Given this list of marker genes SCN5A, TRPC1, RFC5, COL9A3, LTBR, DSG2, ROR2, PIR, RAD9A, DEFB4A, SH3GL2, KCNK1, LAMA2, SMAD3, MYOM1, KIR3DL1, KLK6, NCBP1, MAP4K2, GAS6, MZF1, TMED1, ESS2, PDE1B, SLC11A1, BMP1, S100A3, CDKL1, BDKRB2, GET3, ALDH3A1, TBL3, PTGS1, PFKL, ADGRE1, CSPG4, DBN1, LILRB1, NDN (necdin, MAGE family member), TRIM21, ACE, SLC25A1, OGG1, here is a description of the gene set: Human Gene Set: MODULE_70 Genes in the cancer module 70. species: Homo sapiens